The following is a description of a gene set: Reactome Pathway: Retinoid metabolism disease events part of: Diseases associated with visual transduction species: Homo sapiens Retinol binding protein (RBP4) delivers all-trans-retinol (atROL) from liver stores to peripheral tissues. Defects in RBP4 cause retinol-binding protein deficiency (RBP deficiency, MIM:180250), causing night vision problems and a typical 'xerophthalmic fundus' with progressive atrophy of the retinal pigment epithelium (RPE)., and this is the list of marker genes: RBP4